Given this list of marker genes CACTIN, ISG15, NLRC5, EIF4E2, GIGYF2, USP18, PTPN2, DCST1, YTHDF3 (YTH N6-methyladenosine RNA binding protein F3, NCBI Gene Id 253943), OAS3, MIR21, OAS1, MUL1, SMIM30, SAMHD1, STAT2, TREX1, METTL3, MMP12, TTLL12, YTHDF2, ADAR, CNOT7, here is a description of the gene set: Any process that decreases the rate, frequency or extent of a type I interferon-mediated signaling pathway. Human Gene Set: GOBP_NEGATIVE_REGULATION_OF_TYPE_I_INTERFERON_MEDIATED_SIGNALING_PATHWAY studied in species Homo sapiens